The following is a description of a gene set: Human infertility and recurrent pregnancy loss caused by implantation defects are poorly understood. Hoxa-10-deficient female mice have severe infertility and recurrent pregnancy loss due to defective uterine implantation. Gene expression profiling experiments reveal that Hoxa-10 is an important regulator of two critical events in implantation: stromal cell proliferation and local immunosuppression. At the time of implantation, Hoxa-10 mediates the progesterone-stimulated proliferation of uterine stromal cells. Hoxa-10 mutants express a stromal cell proliferation defect that is accompanied by quantitative or spatial alterations in the expression of two cyclin-dependent kinase inhibitor genes, p57 and p15. Hoxa-10 deficiency also leads to a severe local immunological disturbance, characterized by a polyclonal proliferation of T cells, that occurs in place of the normal progesterone-mediated immunosuppression in the periimplantation uterus. Human Gene Set: YAO_TEMPORAL_RESPONSE_TO_PROGESTERONE_CLUSTER_5 from publication Yao MW, Lim H, Schust DJ, Choe SE, Farago A, Ding Y, Michaud S, Church GM, Maas RL (PMID 12554760) Genes co-regulated in uterus during a time course response to progesterone: SOM cluster 5. studied in species Mus musculus, and this is the list of marker genes: BEX1, BPIFA2, KLF4, KLF10, CYP2E1, USP2, KCNQ1, CNDP2, PER1, CX3CL1, BASP1, COL15A1, PPTC7, COL5A2, HOXA11-AS, NDUFB2, S100G, VEGFA, RELN, ADM, GAP43, LCN2, IER3, MSRB1, ISG20, XDH, PCK1, IL18R1, WWC1, HSPA1A, ATF3